Given this list of marker genes Ctnnb1, Adam19, Ilf3, Angptl4, Jup, here is a description of the gene set: electronically inferred by orthology from the curated human pathway part of: Regulation of Homotypic Cell-Cell Adhesion This event has been computationally inferred from an event that has been demonstrated in another species.<p>The inference is based on the homology mapping from PANTHER. Briefly, reactions for which all involved PhysicalEntities (in input, output and catalyst) have a mapped orthologue/paralogue (for complexes at least 75% of components must have a mapping) are inferred to the other species. Reactome Pathway: Regulation of Expression and Function of Type II Classical Cadherins studied in species Mus musculus